Given this list of marker genes KCNQ1, BICD2, COMP, NPPA, KCNE1, PYGM, PYGL, SLC22A12, COL9A1, SCN5A, COL9A3, SVIL, COL9A2, SLC2A9, here is a description of the gene set: Postexertional symptom exacerbation studied in species Homo sapiens Post-exertional symptom exacerbation (PESE), also referred to as post-exertional malaise (PEM), is defined as the worsening of symptoms that can follow minimal cognitive, physical, emotional, or social activity, or activity that could previously be tolerated. Symptoms typically worsen 12 to 72 hours after activity and can last for days or even weeks, sometimes leading to a relapse. Human Gene Set: HP_POSTEXERTIONAL_SYMPTOM_EXACERBATION